The following is a description of a gene set: studied in species Homo sapiens from publication Pepper C, Ward R, Lin TT, Brennan P, Starczynski J, Musson M, Rowntree C, Bentley P, Mills K, Pratt G, Fegan C (PMID 17287849) CD38 expression is an important prognostic marker in chronic lymphocytic leukemia (CLL) with high levels of CD38 associated with shorter overall survival. In this study, we used gene expression profiling and protein analysis of highly purified cell-sorted CD38(+) and CD38(-) chronic lymphocytic leukemia cells to elucidate a molecular basis for the association between CD38 expression and inferior clinical outcome. Paired CD38(+) and CD38(-) CLL cells derived from the same patient were shown to be monoclonal by V(H) gene sequencing but despite this, CD38(+) CLL cells possessed a distinct gene expression profile when compared with their CD38(-) sub-clones. Importantly, CD38(+) CLL cells relatively over expressed vascular endothelial growth factor (VEGF) and appeared to preferentially utilize an internal autocrine VEGF survival loop. Elevated VEGF expression was associated with increased expression of the anti-apoptotic protein Mcl-1. Inhibition of VEGF receptor signaling also resulted in a reduction in cell viability. In contrast, exogenous VEGF caused a significant increase in CD38(-) CLL cell viability and a marked induction of Mcl-1; both effects were less obvious in CD38(+) CLL cells. Taken together, our data provide a biological rationale for the poor prognosis of CD38(+) CLL and indicate that both VEGF and Mcl-1 may prove to be useful therapeutic targets. Genes down-regulated in CD38+ CLL (chronic lymphocytic leukemia) cells. Human Gene Set: PEPPER_CHRONIC_LYMPHOCYTIC_LEUKEMIA_DN, and this is the list of marker genes: PROS1, NEURL1, IL33, OR3A2, HMGB1P17, ADCY8, CDC14A, EXT1, NEFL, GNRH2, CHST8, LINC03050, NR5A2, SLC10A1, APBB2, GYPA, STATH, PDAP1, CCR4, CENPQ, TBXA2R, PDE10A, MICAL2